Given this list of marker genes Ftl2-ps, Golgb1, Stx4a, Clvs2, Vamp8, Clvs1, M6pr, Ap1s3, Necap1, Gns, Fth1, Snx2, App, Vamp2, Ap1g2 (adaptor protein complex AP-1, gamma 2 subunit), Hgs, Clta, Cltb, Dtnbp1, Ap4e1, Txndc5, Napa, Picalm, Sort1, Cpd, Ap1m2 (adaptor protein complex AP-1, mu 2 subunit), Tpd52l1, Tpd52, Dnajc6, Ap1m1 (NCBI Gene Id 11767), Arrb1, Gbf1, Ap4m1, Arf1, Hip1r, Ap1s1, Clint1 (clathrin interactor 1), Ctsz, Bloc1s4, Ocrl, Ap1g1, Rab5c, Acbd3, Gak, Ap1b1, Cltc, Sh3d19, Chmp2a, Bloc1s3, Sh3gl2, Ap1s2 (adaptor-related protein complex 1, sigma 2 subunit), Snx9, Dnm2, Snap23, Ap3b1, Yipf6, Hspa8, Ap4s1, Snx5, Tfrc, Dnase2a, Ap3s1, Tgoln1, Bloc1s6, Igf2r, Bloc1s1, Tbc1d8b, Pum1, Ap4b1, Pik3c2a, Snapin, here is a description of the gene set: studied in species Mus musculus trans-Golgi Network Vesicle Budding Mouse Gene Set: REACTOME_TRANS_GOLGI_NETWORK_VESICLE_BUDDING